Given this list of marker genes Gbp2, Cp, Ubd, Serpina3n, H2-T23, Hp, Abca1, Cidec, Col15a1, Ifngr1, Stat1, H2-K2, Ltc4s, Pck1, Acox1, H2-D1, Tap2, Hipk3, here is a description of the gene set: from publication Ruan H, Pownall HJ, Lodish HF (PMID 12732648) Adipocyte abundant genes up-regulated in 3T3-L1 cells (fibroblasts induced to differentiate to adipocytes) in response to troglitazone and TNF. Mouse Gene Set: RUAN_RESPONSE_TO_TNF_TROGLITAZONE_UP species: Mus musculus Troglitazone (TGZ), a member of the thiazolidinedione class of anti-diabetic compounds and a peroxisome proliferator activator receptor-gamma (PPAR-gamma) agonist, restores systemic insulin sensitivity and improves the full insulin resistance syndrome in vivo. The mechanisms underlying its in vivo function are not understood. Here we investigated the potential functional interaction between PPAR-gamma and NF-kappaB in adipocytes. We show that TGZ selectively blocked tumor necrosis factor-alpha-induced and NF-kappaB-dependent repression of multiple adipocyte-specific genes and induction of growth phase and other genes. This occurs without interfering with NF-kappaB expression, activation, nuclear translocation, or DNA binding and without suppressing NF-kappaB-dependent survival signals. Notably, the expressions of some tumor necrosis factor-alpha-induced genes in adipocytes were unaffected by PPAR-gamma activation. In reporter gene assays in HeLa cells, ectopic expression of PPAR-gamma abolished induction of a NF-kappaB-responsive reporter gene by the p65 subunit (RelA) of NF-kappaB, and the inhibition was further enhanced in the presence of TGZ. Conversely, overexpression of p65 inhibited induction of a PPAR-gamma-responsive reporter gene by activated PPAR-gamma in a dose-dependent manner. The inhibitory effect was independent of the presence of NF-kappaB-binding sites in the promoter region. Other NF-kappaB family members, p50 and c-Rel as well as the S276A mutant of p65, blocked PPAR-gamma-mediated gene transcription less effectively. Thus, p65 antagonizes the transcriptional regulatory activity of PPAR-gamma in adipocytes, and PPAR-gamma activation can at least partially override the inhibitory effects of p65 on the expression of key adipocyte genes. Our data suggest that inhibition of NF-kappaB activity is a mechanism by which PPAR-gamma agonists improve insulin sensitivity in vivo and that adipocyte NF-kappaB is a potential therapeutic target for obesity-linked type 2 diabetes.